The following is a description of a gene set: species: Homo sapiens from publication Jiang C, Chao CC, Li J, Ge X, Shen A, Jucaud V, Cheng C, Shen X (PMID 38455971) Tissue-resident memory T cells (TRM) are a specialized T cell population residing in peripheral tissues. The presence and potential impact of TRM in the tumor immune microenvironment (TIME) remain to be elucidated. Here, we systematically investigated the relationship between TRM and melanoma TIME based on multiple clinical single-cell RNA-seq datasets and developed signatures indicative of TRM infiltration. TRM infiltration is associated with longer overall survival and abundance of T cells, NK cells, M1 macrophages, and memory B cells in the TIME. A 22-gene TRM derived risk score was further developed to effectively classify patients into low- and high-risk categories, distinguishing overall survival and immune activation, particularly in T cell-mediated responses. Altogether, our analysis suggests that TRM abundance is associated with melanoma TIME activation and patient survival, and the TRM-based machine learning model can potentially predict prognosis in melanoma patients. Human Gene Set: JIANG_MELANOMA_TRM11_CD8, and this is the list of marker genes: CAPG, XCL2, IFNG, CKLF, TRG-AS1, CTSW, CCL4L2, ZNF683, XCL1, THEMIS, ITGAE, ITGA1, UBXN11, ALOX5AP, CD160, MT-ND4, ABI3, PTGER2, RASGEF1B, VIM, CCL5, TMIGD2, NR4A3, TNFSF9, NR4A1, LGALS1, CD8A, LDLRAD4, PDCD4, RUNX3, CD8B (NCBI Gene Id 926), KLRD1, SPRY1, GZMM, LINC02446, AOAH, NR4A2, GPR15, CD244, CD63, ITM2C, LINC01871, HOPX, NKG7, FASLG, GABARAPL1 (GABA type A receptor associated protein like 1), PTGER4, GADD45B, CCL4